The following is a description of a gene set: Any process that modulates the frequency, rate or extent of muscle hypertrophy. species: Mus musculus Mouse Gene Set: GOBP_REGULATION_OF_MUSCLE_HYPERTROPHY, and this is the list of marker genes: Lmcd1, P2rx4, Agt, Mstn, Ppp3ca, Trim63, Mtor, Trip10, Gsk3b, Acacb, Zfp418, Foxp1, Ccn4, Igfbp5, Atp2b4, Smad4, Ptk2, Rgs4, Rbm10, Pde9a, Ece1, Slc9a1, Parp2, Bmp10, Trpc3, Foxo1, Yy1, Edn1, Hamp, Sirt1, Camk2d, Ppara, Errfi1, Igf1, Twf1, Nr4a3, Akap1, Pak1, Rock2, Pi16, Ep300, Nr3c1, Jarid2, Adra1a, Kcnn4, Tomm70a, Mymk, Mtpn, Mef2a, Adcy10, Mef2c, Gsn, Ctdp1, Smad3, Becn1, Cav3, Prkca, Pde5a, Slc25a4, Stub1, Fbxo32, G6pdx (glucose-6-phosphate dehydrogenase X-linked), Lmna, Nfatc3, Pin1, Gsk3a, Tnfrsf1a, Fdps, Tnfrsf1b, Gdf1, Hand2, Ddx39b, Glrx3, Akap6, Mlip, Adk, Rgs2, Adrb1, Cdk9, Pin1rt1, Gata5 (GATA binding protein 5), Notch1, Rock1, Hamp2, G6pd2, Parp1, Pparg